The following is a description of a gene set: from publication Chen Y, Wang X (PMID 31504780) Human Gene Set: MIR6127 Genes predicted to be targets of miRBase v22 microRNA hsa-miR-6127 in miRDB v6.0 with MirTarget v4 prediction scores > 80 (high confidence targets). studied in species Homo sapiens, and this is the list of marker genes: PAICS, EYA3, KLK4, KIF24, CREB3L1, ENAM, RNF169, DNAJB2, MPIG6B, GPATCH8, SPINK14, NAA50, ALKBH1, CWC27, RAB5B, OPN4, CHRDL1, CD34, WDTC1, STAT6, CANX, EPO, ADAM30, NELFE, GABRG2, CDK5R2, VTI1A, NUDT18, BAZ2A, FRY, MAPRE1, CERS3, NDST1, DLX6, PSME3, LSAMP, FOXL2NB, NIPSNAP1, AGAP1, JADE2, LPXN, SLC25A24, IFFO1, DNAH8, PABPC1L2A, MMP19, RCOR1, DEFB118, RPH3A, KLC4, IL2RG, GTF2A1, MECP2, FBXO45, DCX, CSNK1G1, XYLB, TTYH3, OSBP, MAPK14 (NCBI Gene Id 1432), CLSTN3, GATAD2B, MSI1 (NCBI Gene Id 4440), CASTOR2, ACKR2, CERS2, IGSF8, SHF, MVB12B, TRIM16, ETF1, SMAD3 (NCBI Gene Id 51521), ZNF703, XPR1 (xenotropic and polytropic retrovirus receptor 1), BICDL1, LDLRAD3, POU2AF1, NABP2, LHX2, NHLH1, SIX2, EIF4EBP1, PAK3, S100A16, PARD3B, TAB1, ADGRF2P, NOL4L, LINC03040 (long intergenic non-protein coding RNA 3040), RSPO4, IKBKE, SMIM24, N4BP1, JCAD, INTS6, ZNF782, ARL8A, ZNF395, SPRY4, NFIX, SLC9A8, PLA2G2D, PPP1R12B, C20orf96, FGD1, PIANP, SHMT2 (NCBI Gene Id 6472), NOVA2, TET3, CLTA, PAX5, WBP2, KIAA0513, IGF1R, DNMT3B, DPF1, SYNGAP1, SMOC1, MMACHC, SLC2A3 (NCBI Gene Id 94827), KCNQ4, ACVR2A, DTX4, PADI2, HOXC6, VCF2, F9, PACS1, BCL11A, ZDHHC3, ELMOD1, HERC1, ARHGAP19, TTBK1, SAMD9, IL18R1, SHB, AKAP13, TMEM169, YEATS4, IL10RA, MSH5, MIP, GSK3A, PTMS, HYCC2, SP1, RBMS3, ATAT1, RASSF3, MAPKAPK2, ST3GAL1, TRIM16L, ATP1B2, KRT75, DUSP26, PRR29, FIGNL2, TOLLIP, KIF5A, TUBB, WNT7B, NEMP2, SHE, PABPC1L2B, PLXNA4, CENPP, GMPPB, LIMD2, GEN1, EXOC2, SORL1 (NCBI Gene Id 6653), ABHD2, FRMPD3, SLC19A3, CDK1, SHLD1, ADAM19, KCND1, NOTCH3, KCNF1, KDELR2, ZNF583, MICALL1, STX2, NME9, LRATD2, NKD1, ERI3, STING1, SIGLEC1, LENG8, ZFPL1, CCDC184, RAB11FIP1, KSR2, NYNRIN, BPIFB2, CAMKMT, SNX33, LASP1, SMG6, UBL4A, SDK1, ALOXE3, NXF1, FAM131C, LURAP1, ATP6V1B2, UBQLN2, CACNG6, ATP13A3, GJB3, STUM